Given this list of marker genes Vmn1r205, Vmn1r52, Vmn1r201, Vmn1r216, Vmn1r196, Vmn1r4, Vmn1r188, Vmn1r19, Vmn1r84, Vmn1r73, Vmn1r66, Vmn1r70, Vmn1r190-ps, Vmn1r26, Vmn1r54, Vmn1r215, Vmn1r189, Vmn1r41, Vmn1r23, Vmn2r1, Vmn1r40, Vmn1r231, Trpc2, Vmn1r74, Vmn1r219, Vmn1r51 (vomeronasal 1 receptor 51), Vmn1r47, Vmn1r30, Vmn1r230, Vmn1r218, Vmn1r191, Vmn1r232, Vmn1r211, Vmn1r50, Vmn1r21, Vmn1r5 (NCBI Gene Id 171192), Vmn1r45, Vmn1r9, Vmn1r210, Vmn1r38, Vmn1r192, Vmn1r67, Vmn1r237, Vmn1r220, Vmn1r7, Gng8 (NCBI Gene Id 14709), Vmn1r89, Vmn1r35, Vmn1r229, Vmn1r83, Vmn1r42, Vmn1r193, Vmn1r80, Vmn1r227, Vmn1r195, Vmn1r199, Vmn2r26, Vmn1r228, Vmn1r197, Vmn1r81, Vmn1r202, Vmn1r78, Vmn1r49, Vmn1r75, Vmn1r208, Vmn1r6, Vmn1r22, Vmn1r213, Vmn1r234, Vmn1r53, Vmn1r222, V1ra8, Vmn1r17, Vmn1r206 (NCBI Gene Id 171250), Vmn1r28, Vmn1r87, V1rg10, Vmn1r226, Vmn1r8, Vmn2r116, Vmn1r37, Vmn1r203, Vmn1r43, Vmn1r185, Vmn1r36, Vmn1r82, Vmn1r212, Vmn1r217, Vmn1r233, Vmn1r235, Tmem145, Vmn1r46, Vmn1r236, Gpr180, Vmn1r48, Vmn1r18, Vmn1r33, Vmn1r27, Vmn1r44, Vmn1r214, Vmn1r32, Vmn1r16, Vmn1r24, Vmn1r200 (vomeronasal 1 receptor 200), Vmn1r76, Vmn1r225, Vmn1r198, here is a description of the gene set: species: Mus musculus Any process that results in a change in state or activity of a cell or an organism (in terms of movement, secretion, enzyme production, gene expression, etc.) as a result of a pheromone stimulus. Mouse Gene Set: GOBP_RESPONSE_TO_PHEROMONE